Given this list of marker genes Ighg2b, Rnase6, Bmp7, Adamts9 (ADAM metallopeptidase with thrombospondin type 1 motif 9), Cd1d2, Col4a4, Il24, Tnn, Fgb, Cma2, Fcgbpl1, Defa29, Ifna12, Prss21, 5430402E10Rik, Plg, Qsox1, Prl3b1, Lyz1, Wfdc18, Tfpi2 (NCBI Gene Id 21789), F3, Afp, Cd274, Gkn3, Defa35, Ndp, Ccl8, Prss22, F7, Orm1, Ifna7, Habp2, Apol11b, Reg3b, Timp1, Defa23, Ceacam16, Mfap4, Bhmt1b (betaine--homocysteine S-methyltransferase 1B), Ctsw, Ltb, Vmo1, H2-Q4, Jam3, Tnf, Prss46, Mmp28, Aqp1, Olfm1, Serpina1a, Col4a2, Pip, Plod1, Orm2, Serpine2, Hba-a1, Bpifa5, Hpse2, Sparc, Ccl6, Fgf4, Col17a1 (collagen, type XVII, alpha 1), Fam20a, Man2b1, Rbmx, Ctsh, Tafa3, Apol10a, Metrnl, Bpi, Nos2, Aldoa, Sostdc1, Ccl27a, Serpinb10, Pebp1, Cpa4, Tff1, Grem1, Saa2, Tff3, Cxcl9, Gsdmd, Hbb-bh2, Dnajc9 (NCBI Gene Id 68076), Rspo4, Ang4, Gzme, Apcs, Dpysl3, Plod2, Pglyrp1, Enpp1, Apoc3, Prss28, Muc2, Cmtm2a, Umodl1, Ulbp1, Pbsn, Scg2, Bmp8a, Tnfrsf1a, Tnfsf10, Wfdc16, Spock3, Il7, Il20, Pth, Pgk1, Pnlip, Afm, Apoe, Tectb, Stx4a, Pdcd6ip, Fn1, Serpina5 (NCBI Gene Id 268591), Zp3r, Ccl25, Klk1b3, Chia1, Lamc2, Ctsll3, Prl3c1, Cyp4a14, Npc2, Fuca2, Cela3a, Dcpp2, Tinagl1, Il6ra, Vcan, Serpina3i, Gpx3, Cfhr2, H2-Q7, Ear2, Gsn, Defb43, Smoc2, Nrros, Btc, Defa24, Stfa1, Xylt2, Ebi3, Ctsq, Pkhd1, Ctss, Klk1b24, Creg1, Cst5, C8a, Cpa1, Il18bp, Pdgfb, C1qtnf6, Prl3a1, Defb1, Colq, Lrp8, Lrrn3, Nog, Igfbp4, Mill2, St14, Ccl24, Mmp17, Fgf17, Ghr, Colec11, Cstdc3, Col14a1, Prl8a6, Apoc1, Klk1b27, Pon3, Pcsk6, Cubn, Csf1, Ptprg, E130311K13Rik, Mup9, Klk13, Vash1, Pgc, Epx, Uts2, Scnn1b, Prss44, Mir106a, Spink1, Shh, Prss1, Defa40, Pltp, Cpz, Prss1l, Sri, Igha, Rab5b, Scgb3a2, Xylt1, Tnfsf8, Klk1b5, Apoc2, Igkv18-36, Gp2 (NCBI Gene Id 67133), Thbd, Ide, Defa5, Mup4, Rtn4rl2, Hp, Serpina16, Ckm (NCBI Gene Id 12715), Mptx2, Hjv, Fbn2, Fgf1, Dspp, Ear10, Klk1b11, Mpo, Prss30, Prss29, Gdf10, Gzmc, Efemp1, Adamts13, Defb48, Mmp11, Scgb1a1, Ppp1r1a, Ccn5, Matn2, Atp6ap2, F5, Mtcl3, F12, H2-M10.5, F9, Smoc1, Vegfb, Rap1gds1, Gzmb, Mcam, Orm3, Vldlr, Gprc5c, Csn3, Prg4, Tfpi, Csn1s2a, Ahnak, Otogl, H2-M10.4, Serpinb9g, Muc1, Mup14, Proc, Sema4d, B2m, S100a4, Il17c, Obp1b, Slmap (sarcolemma associated protein), Insl3 (insulin-like 3), Col9a1, Lama5, Lrrc24, Cxcl10, Gla, Col5a1, Svs3b, Lcn2, Grem2, Mir17, Tnxb, Gars1, Gdf3, S100a7l2, Klk10, Loxl3 (NCBI Gene Id 16950), Actg1, Mir26b, Fam3d, Hpse, Bsph1, Crlf1, Slc12a1, Cr1l, Ccl17, Prss3, Gcg, Fshb, Klk14, Alkal2, Csn2, Gzmk, Stx2, Egf, Ccn2, C1qtnf1, Hspbp1, Crtap, Ctf1, Tnfrsf11b, Gdnf, Otog, Lyz3, Meltf, Wnt2b, Gpt, Plat, Wfikkn2, Amy2a5, Ptprz1, Dkk1, 2310057J18Rik, Mt3 (NCBI Gene Id 17751), Gprc5d, Apod, Hexb, C1qtnf12, Wfdc17, Muc13, Tnr, Ifna5, Ceacam1, Pdgfd, Tnfsf15, Crispld1, Klk1b9, Il23a, Lgi1, Alpl, Lrg1, Col11a2, Tnfsf11, Csta3, Cuzd1, Gal, Adm, Pspn, Svs3a, Fap, Eln, Hmgn2-ps, Ntf5, Rap2b, H2-K1, Nepn, Tslp, Rnaset2b, Fbn1 (NCBI Gene Id 99016), Mir26a-2, Pdia4, Dmbt1, Il36g, Cfd (NCBI Gene Id 11537), Sulf2, Gas6, Cd47, Zg16, Angptl3, Gkn1, Flrt1, Mbl1, Aga, Cer1, H2bc12, Cpa3, Lingo1, Tgfb1, Cpxm2 (NCBI Gene Id 78756), Gpha2, Ccl11, Il18, Semg1, Lilra5, Areg, Lgi2, Tacstd2, Fcgr4, Ctf2, Timp3, Tafa5, Cp, Wnt7a, Podxl, Serpinb9c, Alpi, Obp2b, Reg4, Gdf6, Esp24, Ifng (NCBI Gene Id 15978), Pank4, Entpd5, Mydgf, Cstdc4, Prss3l, Serpind1, Fbp1, Glb1l, Hmgn2, Lrrc3c, Lefty1, Lcn3, Clic1 (chloride intracellular channel 1), Sfrp2, Plbd1, Olfml2a, Arg1 (NCBI Gene Id 11846), Prom1, Fgf16, Spinkl, Ang, Col3a1 (NCBI Gene Id 98713), Sorl1, Cfh, Adam9, C1ql4, Gprc5b, Retnlg, Chad, Fst, Il1f10, Wfdc6b, Gkn2, Pdyn, Bmp8b, Lpl, Reg3d, Lrrc32, Cela3b, Apol9b, Angptl6, Ctsf (NCBI Gene Id 56464), Hpgd, Krt13 (keratin 13), Igfbp7, C1qtnf9, Mcpt1, Hbegf, Tgfb3, Abcb6, Crisp3, Serpinb1b (serine (or cysteine) peptidase inhibitor, clade B, member 1b), Col9a3 (NCBI Gene Id 99252), Fga, Ang6, Pdgfa (NCBI Gene Id 18590), Nrg2, Wnt9a, Ccn3, Hapln3, Kars1, Pcdh15, Ifna1, Lrrc3b, Cpb2, Scgb2b20, Col23a1, Il9, Ctso, Nenf, Sema3a, Serpinb9b, Chid1, Col10a1, Il27, Col25a1, Bmper, Ifna6, Agrn, Cklf, Tac1, Pate14, Apoa2, Clec11a, Lrig1, Cts8, Gdf1 (NCBI Gene Id 14559), Ggh, Naxe, Serpina1d, Pkd1 (polycystin 1, transient receptor potential channel interacting), Defb11, H2-M3, Kng1 (kininogen 1), Il36rn, Tcn2, Cxcl12, Ighm, Dag1, Slit3, Bmp2, Ins2, Cilp2, Cst7, Ighg1, Fgf8, Prss56, Stfa2, Mmp9, Pcmt1, Sval1, Chil5, Defa36, Ccn6, C1qtnf7 (NCBI Gene Id 78661), Gdf15, Mup18 (NCBI Gene Id 100048884), Chi3l1, Tmprss4, Gm14744, Spock1, Klk11, AY761185, Sfrp5, Axl, Serpinb9e, Agt, Serpinb13, Itga2b, Tsg101, Anxa1, Gh, Hdgf, Fgf9, Cyp4a30b, Serpinf2, Il16, Ptx3, Colec10, Amy2a3, Aspn, Pxdn, Gm5938, Glb1, Bpifa1, Crisp1, Cstdc5, Wnt16, Ccr3, Thpo, Il6st, Tsku, Marco, C4b, Crh, H2-M10.2, H2bc21, Fstl3, Mmp3, Dkkl1, H2-Q10, 2410137M14Rik, Serpinh1 (serine (or cysteine) peptidase inhibitor, clade H, member 1), Olfml3 (NCBI Gene Id 99921), Clec18a, Emilin1, Mcpt2, Scgb3a1, Gpr15lg, Tnfaip6, Wfdc21, Man2a1, Klk1b22, Dkk3, Igkv3-12, Mup10 (major urinary protein 10), Ccl12, Cpq, Igfl3, Prl8a8, Aqp2, Prl8a9, Ist1, Esp4, Tfrc, Ccl3, Svs4, Nsun2, Pf4, Podnl1, Muc5b, Rspo2, Prl7a1, Prss23, Tctn1, Prl7d1, Prss3b, Lingo2, Mir195a, Sst, Lpo, Adgrb1, Alkal1, Csn1s1, Angpt4, Sema3c, F8, Sema3d, H2bc6, Tpsb2, Esp3, Csta2, Defb6, Csn1s2b, Comp, Gprc5a, Cfhr4, Aoc1l3, Rab11a, Chrd, Nat8f3, Prrg3, Cst3, Adam15, Ttr, Gdf11, Slc26a4, Snca, Defb10, Umod, Serpini2, Tinag, 3110082I17Rik, Zbed3, Avp, Pomc, Prss37, Bmp6, C1qtnf5, H2-T5, Pdap1, Il22, Gdf9, H60b, Susd2, Kif12, F11, Ccl22, Mup22, C1rl, Ctsg (NCBI Gene Id 13035), Wfdc1, Col5a3, Ighe, Lgr6, Lcn4, Esp1, Flrt2, Mmp12, Hyal1, Klk1b21, Lgi4, Gabbr1, Wnt3a, C1qbp, Atrn, Cpa6, Mmp7, Mptx1, Ostn, Krt18, Dkk4 (NCBI Gene Id 234130), Cel, Ear14, Defa41, Psapl1, Mup21, Scube2, Serpinb8, Inhbb, Ccl5, Sema3f, Minpp1, Cmtm5, Ifna2, Prl2a1, Vegfa, Tll1, Lama1, Il1a, Ybx1, Esp31, Ace, Ctsb, Cd59b, Adipoq, Dicer1, Cbln2, Atp5pf, Slit1, Defb7, Try10, Col1a1, Timp4, Ptn, Scgb2a2, Angptl4, Trf, Il17f, Defa38, Il33, Cmtm3, Cxcl16, Reg3a, Ppt1, Vwa2, H2-T23, Eda, Wnt6, Cd109, Adcyap1, Npy, Serpinb6d, Pla2g15, Mcpt4, Entpd6, Tgfbr2, C9orf72, Rnase2a, Edn2, Angptl7, Defb38, Kcp, Smpdl3a, Serpinb5, Bche, Slpi, Dmkn, Defa31, Cpe, Bhmt, Fgf20, Dbh, Wfdc15b, Lipc, Lrrtm1, Prl7b1, Ntm, Saa1, Defa27 (NCBI Gene Id 100041811), Prss51, S100a13, Mmel1, Cstdc2, Clec3b, Lamp2, Pnliprp2, Anxa5, Ada, Spn, Igfbp2, Sod3, Prss32, Ctsm, Spink7, Nid2, Tll2, Mup12, Fam151a, Wnt7b, Mmp8, Icam1, Slurp2, Kazald1, Pyy, Mup19 (major urinary protein 19), Calcb, Mertk, Hmgb2, Prl2c2, Pcsk1, Tgfbi, Klk6, Angpt1, Defa3, Il4ra (NCBI Gene Id 16190), Itm2b, Lif, Naglu, Tgfa, Igkv3-2 (immunoglobulin kappa variable 3-2), Gba1, Klk1, Pcsk5, Il3, Fgg, Prl2c5, Serpinf1, Fgf21, Igkv3-3, Ogn, Erfe (NCBI Gene Id 227358), Olfm4, Kitl, Rarres1, Il1r1, Klk15, Cnp, Cxcl14, Prrg2, Mir16-2, Selenos, Tpsg1, Masp2, Serpina1c, Cfhr1, Prl8a1, Defa21, Il4, Cela2a, Serpini1, Sct, Ccl21a, Igf2, Tgfb2, Ins1, Mmp1a, Tnfsf9 (NCBI Gene Id 21950), Ghrh, Fzd9, Acp3, Cts7, Eppin, C6, Prf1, S100a14, Entpd1, Scube1, Xpnpep2, Itih4, Fbrs, Il12a, Wfdc2, Npff, Bdnf, Lamb1, Defa42, Calca, Angptl1, Vasn, Vnn3, Kera, Gdf2, Il17d, Lbp, Aoc1l1 (NCBI Gene Id 243376), Rbp3, Gldn, Amy2a1, Sell, Ambp, Il15, Gfra4, Itln1, Cst9, Esp34 (NCBI Gene Id 100126773), Ifnab, Gm13271, Alad, Hamp2, Pdia3, Gzmd, Serpina3m, Serpina1f (NCBI Gene Id 68348), Igf2r, Serpina3f, Igfbp6, Defa30, Defa25, Cga, Nell2, Wnt1, Mup17, Apln, Mup11, Fasl, Wnt10b, H2-Q6, C1qtnf4, C1qb, Amy2a2, Klk1b1, Crhbp, Ntf3, H2bc13 (NCBI Gene Id 319185), Jchain, Pthlh, Ccl21b, Vnn1, Muc5ac, Ctsr, Cpd, Pla2g1b, Gfra1, Moxd1, Tnfsf12 (NCBI Gene Id 21944), Spp1, Mmrn2, Ifnz, Cxcl11, Wnt11, Hspa8, Ggt1, H2-M2, Cd59a, Wap, Tff2, Lgals1, Serpinb3d, Hmgb1, Nppb, Pzp, Sele, Postn, Cd40lg (CD40 ligand), C1rb, Csta1, Ifna13, Otol1, Il1b, Fetub, Klk7, Apoa4, Cpxm1, Pik3ip1, Svs6, Ifnar2, Mtcl2, Car2, Napsa, Mmp16, Lipe, Gast, Try5, Defb3, Il17b, Scnn1a, Dhh, Xcl1, Cd86, Gpld1, Pon1, Prrg1, H2bc8, Adamts5, Efemp2, Gdf5, Cblif (NCBI Gene Id 14603), Iapp, Csf2, Bgn, Hpx, Vtn, Lum, Btd, Fbln5, Serpinb11, Oxt, Tnc, H2bc4, Slit2, Hapln1, Prl7c1, Flt1, Cts6, 6030468B19Rik (RIKEN cDNA 6030468B19 gene), Adamts15, Cts3, Col6a3, Hbb-bt, Ccn4, Lgi3, Ren1, Sfrp1 (NCBI Gene Id 72362), Lyzl4, Crispld2, Mup5, Cxcl2, Serping1, Lepr, Col22a1, Hamp, C3, Fbln1, Igfbp5, Ddx11 (NCBI Gene Id 320209), Chil6, Zpld1, A2ml1, Ctsj, Akr1b1, Ifnl3, Pigr (NCBI Gene Id 18703), Creld2, Aebp1, H60c, Agrp, Defa26, Apoa5, Igf1, Asah1, Fabp3, Col4a5, 4930486L24Rik, Kit, Lgals9, Lingo4, Wnt3 (NCBI Gene Id 22415), Pappa, Mup8, Serpine1, Prss43 (serine protease 43), Mmp24, Fbln7, Lcn5, Col8a2, Dbi, Wfdc11, Igkv3-7, Sema3e, Mmp25, Olfm2, Bmp5, Tafa4, Ctsd, Gpi1, Gm6040, Cma1, Slc2a4 (solute carrier family 2 (facilitated glucose transporter), member 4), Igfals, Procr, Igfbpl1, Anxa2, Srpx2, Cd40, Ifnl2, Itgam (integrin alpha M), Fibcd1, Cmtm8, Tmem98 (NCBI Gene Id 76207), Sod1, Cntf, Dpep1, Prss58, Col6a2, Lcn9, Spx, Lrrc17, Mmp23, Thbs4, Loxl2, Il25, Ccl19, Nrg4, Fgl1, Esp16, C1s2, Hspa1a, Mcpt8, Col27a1, Fgf10, Esp22, Inhbe, Il12b, Pgf, Reg2, Defb33, Selenop, Liph, Il36a, Islr, Prl3d3, Gm44501, Fcgbp, Ibsp, Fndc4, Ces1c, Prss48, Kmo, Psg20, Il11, Olfm5 (olfactomedin 5), 1810009J06Rik, Ager (NCBI Gene Id 11596), Cd180, Artn, Metrn, Slurp1, Fgf7, H2-M11, Ctsl, Erap1, Hgfac, Wnt8a, Prrg4, Apon, Il34, Mir20b, Prss45, BC051665, Sftpa1, Wnt5b, Lrrn2, Dlk1, Inhbc, S100b, Fzd10, Igfbp1, Ecrg4, Cmtm2b, Qsox2 (NCBI Gene Id 227638), Bmp10, Fau, Cpb1, Lefty2, Sfrp4, Irak4, Sval2, Serpina3b, Ghrl, Ceacam2, Mir20a (microRNA 20a), Igfbp3, Pkd2, Stc1, Serpina6, Idua, Serpina9, Lxn, Ace2, Wfdc10, Fgf5, Ifna4, Cfp, Bglap, Defa34, Stfa3, Gm13272, Olfml2b, Tmprss6, Vcam1, F10, Sord, Prss40, Aimp1, Rspo3, Ifnb1, Col12a1, Pla2g7, Prl6a1, Omd, Amy2a4, Mir16-1, C7, Prss42, Defa22, Wnt2, Bpifa2, C2, Mir26a-1, Mr1, Casp7, Serpinb1c, Ndnf, Tpt1, Tshb, Mir451a, Il36b, Il31, Cdh13, C4bp, Cthrc1, Cx3cl1, Lingo3, Reln, Cstdc6, Mup1 (major urinary protein 1), Prelp, Mir106b, Ocm, Zp3, Gpc4, Fstl1, Csf3, Psap (NCBI Gene Id 19156), Rnpep, Serpine3, Rnls, Elane, Clec2g, Apobr, Serpinb3a, Vegfc, Crisp2, Mmp19, Cfi, Cr2, AY074887, Apol10b, H2-M10.1 (histocompatibility 2, M region locus 10.1), Ltf, Cort, Hbb-bs, Enpp2, Ang5, Apela, Serpina11, Cxcl5, Lgals4, U90926, Wfdc5, Clu, Lta (lymphotoxin A), Ctsc, Cripto, Vwf, Col13a1, Clec3a, Defa17, Ccl2, Adnp, Trem1, Ckb, Defa28, Hdlbp, Bricd5 (NCBI Gene Id 319259), Tpsab1, Prss33, Fgf18, Muc4, Pate6, Bglap2, Copa, Sspo, Ifna15, Lrp2, Serpina1b, Serpina3g, Fam3a, Lox, Col19a1, C8g, Car6, Ccl20, Serpina3a, Osm, Serpinb1a, Serpinb3b, Ldlr, Bmp4, Defb47, Gp1ba, Rbmxl1, Col2a1, Arhgdia, Gm13283, Esp8, Tg, Mmp2, Ear1, Mup7, Cbln3, Defb39, H2-M10.6, Reg3g, Cpa2, Gdf7, Prl2b1, Ctsz, Ptgis, Ccl7, Col28a1, Clcf1, F2, Ccn1, Gzmf, Dnajb11, Lsr, Ssc5d, Muc6, Nrg1, Rpl39, Pmch, Cd9, Nucb2, Ifna16, Fmod, Esp23, Obp1a, Mst1, Gnrh1, Wfdc13, Mup6 (major urinary protein 6), Fam3b, Wfdc12, Alb, Fam20c, Cstb, Col5a2, Prl5a1, H2-Q1, Fabp5, Sparcl1, Mmp13, Serpina3n, Rspo1, Nell1, Ddt, Scube3, Ache, Esp18, Amh, Srgn, Bmp3, Hfe, Lypd8, Il2, Mfge8, S100a7a, Cmtm7, Gip, C8b, H2-T22, Fcna, Dcn, C4a, Ighg2c, Defa39, Rnase4, Sulf1, Lep, App, Fgf23, Klkb1, Bpifc, Serpinb9h, Serpina3k, Serpinb12 (serine (or cysteine) peptidase inhibitor, clade B (ovalbumin), member 12), Hgf (hepatocyte growth factor), Cpn1, Sval3, Ppia, Selp, Fgf6, Il1rl1, Glipr1, Smpd1, H2-M1, Fas, Aoc3, Nppa, Apom, Cartpt, Tnfsf18, Pla2g2a, Klk4, Nat8f5, Nmb, Mill1, Lipi, H2-M9, Serpina10, Myoc, Svep1, Hspd1, Mup15, Chil4, Gzma, Pcolce, H2-M10.3, Adamts20, Arsa, Mup20, Olfm3, Prdx4, Retn, Prl2c1, Fjx1, Serpinb6b, Arsg, Pcyox1, a, Pcsk2, Ucn2, Epgn, Cxcl13, Acan, Wfdc9 (NCBI Gene Id 634940), Il1rn, Vwc2l, Krtdap, Moxd2, Il5, Lyz2, Raet1e, Tafa1, Ngf, Gzmn, Glipr1l2, C1qa, Fkrp, Fgf15, Dand5, Gcnt1, Cd74, Lnpep, Prss57 (serine protease 57), Hilpda, Gm14743, Cxcl1, Cd46, Stc2, Lcn12, Pecam1, Cxcl15, Col8a1, Ccl28, Amy1, Mstn, Defa37, Klk1b26, R3hdml, Col24a1 (NCBI Gene Id 71355), Lrrc15, Msr1, Nrtn, Chil3, Anpep, Elfn1, Nrg3, Hapln2, Fgf2, Gm2663, Sftpc, Npb, Glipr1l3, Fgl2, H2-T3 (NCBI Gene Id 547339), Klk8, Havcr1, Egfl7, Il19, Mmp14, Klk1b8, Oit3, Mup13, Gusb, Wnt9b, A2m, Cpm, Gpt2, Pros1, Pla2g6, Cela1, Podn, Camp, Tnfsf4, Raet1d, Serpina1e, Wnt4, Cyp4a12a, Try4 (trypsin 4), Defb2, Fam3c, H2-T13 (histocompatibility 2, T region locus 13), Nbl1, Sva, Dcpp1, Calr, Scgb2b2, Obp2a, Cck, Lcat, Masp1, Stfa2l1, Mmp15, Fcnb, Serpinb6c, Esp36, Saa3, Ero1a, Bcan, Flt3l, Plaa, Tgfbr3, Apoc4, Lrrtm4, Aoc1l2, Tnfsf13b, Mug2, Prl7a2, Tpo, Serpina3c, Cpa5, Spag11a, Col4a1, Col16a1, Prss2, Esp15, Nat8f2, Pmel, Chga, Cyp4a12b, Ccl4, Serpinb7, Hc, Ifna11, Rab4a, Prss59, Col9a2, Defa2, Lhcgr, Il21, Asah2, Prtn3, Dipk2a, Mbl2, Wfikkn1, Prl3d1, Ncan, Inhca, Kiss1, Bmp15, Apoh, Igkv3-1, Il13, Lipg, Lgals3, Il22b, Gm13275, Grp, Tac4, Ptgds, Ifi35, Prss39, Ppy, Cpn2, Lrrtm2, Proz, Angpt2, Zpld2, Glipr2, Ang2, S100a9, Ccl1, C1qc (NCBI Gene Id 12262), Nrn1, Pi15, Mup3, Ucn3, Utp11, Odam, Mcpt9, Prl3d2, Loxl1, Nucb1 (nucleobindin 1), Bglap3, Wfdc3, Ifna9, Gm13539 (predicted gene 13539), Prl8a2, Nicol1, H2-T24, Xdh (xanthine dehydrogenase), Ifna14, Spon2, Col6a1, Cxcl17, Mif, Ngp, Ihh, Pnliprp1 (NCBI Gene Id 18946), Rs1, Tnfsf13, Gzmg, Retnla, Inha (inhibin alpha), Adm2, Dao, Aoc1, Mup2, H2-T15, Pate2, Nppc, Pam, Chadl, Sost, Defb9, Defb8, Prl2c3 (NCBI Gene Id 26421), Gphb5, Rbp4, Cxadr, Klk1b4, Serpinb9f, Wfdc6a, Flrt3, Adissp, Glipr1l1, Il17a, Rarres2, Hapln4, Msln, Defb5, Pibf1, Trhde, Klk1b16, Crp, C1ra, Lgals3bp, Tafa2, Ereg, Esp38, S100a16, Vgf, Bmp1, Manf, Nat8f1, Tac2, Plod3, Defa20, Gm13276, Reg1, Serpinb6e, Cdnf, Col7a1, Dkk2 (dickkopf WNT signaling pathway inhibitor 2), Npepps, Svs5, Eng, Edn3, Dcpp3, Mup16, Scgb2b24, Thbs1, Chit1, Samd1, Elfn2 (NCBI Gene Id 278687), Erbb3, Wfdc15a, Lman2, Klk9, Apol8 (apolipoprotein L 8), Defb4, C1s1, Cbln4, Car4, Frzb, Apoc2l, Ifnk, Sftpb, Cd63, Serpinb9, Col15a1, Slc12a3 (NCBI Gene Id 20497), Fgf3, Spock2, Wnt8b, H2-Q2, Gm13277, Nmi, Apol9a, Cxcl3, Azgp1 (NCBI Gene Id 12007), Scara3, H2-M5, Vegfd, Hba-a2, Apoa1, Mgp (NCBI Gene Id 223886), Ccbe1, Zan, Prss34, Cd1d1, Edn1, C9, Prl, Ccl9, Kng2, Epcip, Hnrnpa2b1, Ecm1, Epo (erythropoietin), Defa32, Slc9a3, Col18a1, Retnlb, H2-D1, Ifne, Ramp1, Ighg3, Nrn1l, Ahsg, Prl4a1, Pdgfc, Cd81, Hspa4, C1qtnf3, Ppbp, Nampt (NCBI Gene Id 68683), Bag6, Adprh, Chgb, Snx18, Col1a2, Lrrn1, Crisp4, Serpinb2, Mug1, Igkv3-5, Wnt10a, Pla1a, Lcn11, Vwc2, Serpinc1, Igkv3-9, Serpinb9d (NCBI Gene Id 20726), Apol11a, Acp5, Spint3, Il10, Pirb, Bpifb1, Defb40, Col4a6, Serpina12, Tril, Fam151b, Adamts3, Prss8, Pate4, Igkv3-4, Col11a1, Tnfsf14, Serpina7, Msmp, Mtcl1, Nodal, Serpina3j, Sftpd, Defb37 (NCBI Gene Id 353320), Nudt1, Gpx5, Enpep, Il6, Defb14, Fcgrt, Serpinb3c, Grn, Pappa2, Pcsk9, Rnase2b, Ago2, Ear6, Sbp, Klk5, Smpdl3b, Loxl4, Sbpl, Serpinb6a, Sdcbp, Agr2, Col4a3, Gzmm, Pla2g10, Cyp4a29, Plau, C1qtnf2, Pcsk1n, Adamts4, Apof, Twsg1, Lrrtm3, Obscn, Cd14, Cat, Pi16, Apob (apolipoprotein B), Pm20d1, Amn, Gc, Lhb, Wnt5a, Cilp, Ccl26, Defb46, Lrig2, Nptxr (NCBI Gene Id 74738), Met, Angptl2, Timp2, Inhba, Scnn1g, Igkv3-10, Gfer, Creg2, S100a8, Rnaset2a, Manba, Ctsk, Nyx, Acy1, Pdia6, Klk12, here is a description of the gene set: Mouse Gene Set: GOCC_EXTRACELLULAR_SPACE studied in species Mus musculus That part of a multicellular organism outside the cells proper, usually taken to be outside the plasma membranes, and occupied by fluid.